Given this list of marker genes Efnb1, Map2k2, Efna4 (NCBI Gene Id 13639), Sptbn4, Rps6ka5, Tubb4b, Mapk7, Tln1, Crmp1, Arpc2, Shank3, Tuba1c, Fyn, Vldlr, Fes, Tyrobp (NCBI Gene Id 22177), Rhob, Rasa1, Col6a5, Actr2, Pfn2, Pik3cb, Reln, Actr3, Dok2, Ephb3, Col6a6, Col6a1, Prkaca, Dok1, Ap2b1, Hras, Ptk2, Efnb2, Artn, Itga2b, St8sia4, Dpysl2, Shc3, Col4a2, Tuba8, Nrtn, Plxnd1, Gdnf, Frs2, Sema3a, Mapk3, Ret, Trem2, Pik3r2, Map2k1, Cxcl12, Plxna3, Vasp, Sema4d, Tuba1b, Ptpra, Prkacb, Arpc5, Efnb3, Shc1, Ank1, Lypla2, Dok5, Nfasc, Tuba3b, Dok4, Ap2a1, Tubb2b, Efna2, Grb2, Dpysl5, Cd72, Ngef, St8sia2, Psen1, Gfra2, Cdk5, Egfr, Rdx, Rnd1, Grin2b, Efna5, Col2a1, Ap2s1, Pfn1, Tubb6, Mmp2, Tuba1a, Ubb, Tubb4a, Ncam1 (neural cell adhesion molecule 1), Rps27a, Irs2, Dag1, Epha7 (Eph receptor A7), Sdcbp, Itsn1, Ephb4, Epha2, Dnm2, Pak3, Sptbn2, Col5a3, Csnk2b, Grin1, Gfra1, Arhgef7, Fgfr1, Ap2m1, Cxcr4, Ptprc (protein tyrosine phosphatase receptor type C), Dpysl3, Itga5, Ephb2, Tubal3, Psenen, Cdc42, Ephb6, Tuba4a, Yes1, Prkca, Ranbp9, Pip5k1c, Evl, Gap43, Arpc4, Ephb1 (NCBI Gene Id 270190), Gab1, Numb, Arhgef12, Ntn4, Erbb2, Col9a1, Rras, here is a description of the gene set: part of: Developmental Biology electronically inferred by orthology from the curated human pathway Reactome Pathway: Nervous system development studied in species Mus musculus This event has been computationally inferred from an event that has been demonstrated in another species.<p>The inference is based on the homology mapping from PANTHER. Briefly, reactions for which all involved PhysicalEntities (in input, output and catalyst) have a mapped orthologue/paralogue (for complexes at least 75% of components must have a mapping) are inferred to the other species.